The following is a description of a gene set: studied in species Mus musculus Mouse Gene Set: GOMF_5_3_EXONUCLEASE_ACTIVITY Catalysis of the hydrolysis of ester linkages within nucleic acids by removing nucleotide residues from the 5' end., and this is the list of marker genes: Fan1, Dxo (NCBI Gene Id 112403), Fen1, Mgme1, Cpsf3, Dcp2, Xrn2, Pld4, Dclre1b, Exo5, Trir, Xrn1, Aptx, Exo1, Dclre1c, Exog, Dclre1a, Pld3